The following is a description of a gene set: Reactome Pathway: Glycosphingolipid catabolism part of: Glycosphingolipid metabolism studied in species Homo sapiens Gangliosides (GGs) are glycosphingolipids in which oligosaccharide chains containing N-acetylneuraminic acid (NeuNAc) are attached to a ceramide. Produced in the Golgi, they locate to the plasma membrane, where they contribute to Ca2+ and protein-ligand binding and to the ability of patches of the membrane to experience high curvature topologies, which is essential in many neuronal cells. Degradation of complex polysialylgangliosides starts during endocytosis producing GM1. Inward budding of the late endosomal membrane yields intralysosomal luminal vesicles (ILV) that carry the GGs on the outside of their membranes for final degradation and release to the cytosol. Essential cofactors for lysosomal ganglioside catabolism are the saposins, small carrier proteins which make GGs soluble by providing lipid anchors to move GGs from ILV membranes to the lysosome lumen. Another cofactor is the Ganglioside GM2 activator (GM2A, GM2AP), which is essential for beta-hexosaminidase activity in the degradation of GM2, GA2, and SM2A. Further cofactors appear to be membrane lipids including cholesterol. Lack of any participating enzyme or cofactor leads to the accumulation of glycosphingolipids in lysosomes and sphingolipidoses, including Gaucher's and Niemann–Pick diseases., and this is the list of marker genes: ARSH, ARSG, ARSL, ARSJ, NEU4, GLB1L3, SMPD1, GLB1, STS, ARSB, ARSF, GBA1 (glucosylceramidase beta 1), NEU2, ARSK, HEXB, GBA3, SUMF2, ASAH2, NEU1, CTSA, ARSA, GLA, SMPD4, GALC, PSAP, M6PR, GM2A, SMPD2, NEU3, GLB1L2, ARSD, GBA2, HEXA, ASAH1, SUMF1, GLB1L, ENPP7, ARSI, SMPD3